Given this list of marker genes Lrp1, Tnfrsf1b, Macf1, Map2k2, Xlr3b, Caprin1, Lig4, Cxcr4, Bmpr2, Ptn, Wnt3, Vegfc (NCBI Gene Id 22341), Clcn2, Gsk3b, Smurf1, Twf2, Rheb, Synj1, Robo2, Myc, Pparg, Shtn1, Srf, Mapk8, Hdac6, Plxnb3, Cyfip1 (NCBI Gene Id 29878), Reln, Xrcc6, Dcx, Trim32, Zfp365, Il1rapl1, Golga4, Tiam1, Kdr, Ephb2, Hif1a, Hap1, Amigo1, Gh, Slc7a5, Parp6, Egfr, Aspa, Pafah1b1, Ndel1, Mir124a-3, Qki, Pak3, Anapc2, Nrp1, Mtor, Nap1l1, Il6, Fn1, Nkx2-2, Nin, Bex1, Epha4, Plxnb1, Ptk2, Etv5, Nkx2-2os, Il1b, Gper1, Kras, Prmt5, Plag1, Plxnd1, Fmr1, Vim, Oprm1, Dll3, Tgm2, Tnf, Tle6, Adcy10, Ptpra, Lif, Dlg4, Smo, Bdnf, Fbxo31, Ptprf, Fxr2, Neurl1a, Tnfrsf12a, Rab21, Spint1, Aspm, Map1b, Kit, Tbc1d24, Rufy3, Ilk, Bag1, Bhlhb9, Nr2e1, Trf, Cip2a, Grip1, Bcl11a, Srrt, Itpka, Olig2, Pax6, Igf1, Stau2, Grm5, Hdac1, Opa1, Cx3cl1, Stk11, Zfp335, Rela, Mag, Map3k13, Myo5b, Tlr2, Mdk, Akap5, Caprin2, Itgb1, Marcks, Snw1, Hdac2, Otp, Nkx6-2, Atxn1, Mir124a-2, Prkci, Bin1, Lpar3, Myb, Gfap, Rnf112, Map2k1, Csf1r, Fxn, Apoe, Lrp2, Mup20, Megf8, Metrn, Id2, Mir23a, Dct, Ace, Cdkl5, Faim, Ngf, Mfn2, Drd2, Shh, Pias2, Cxcl12, Robo1, Chodl (NCBI Gene Id 73211), Ntrk3, Disc1, Ache, Mir219a-1, Trpv2, Snap91, Ss18l1, L1cam, Tnik, Wdr62, Sox2, Zfp488, Numb, Ptprd, Bmp2, Dbn1, Eif4g2, Numbl, Vegfa, Smarcd3, Arrb2, Xrcc5, Ufl1, Dixdc1, Sgk1, Lta (NCBI Gene Id 16992), Skil, Obsl1, Ascl1, Wnt2, Kdm1a, Islr2, Eef2k, Star, Man2a1, Lyn, Fbxw8, Crabp2, Pak1, Slitrk1, Cdkl3 (cyclin dependent kinase like 3), Cask (NCBI Gene Id 236691), Plxnc1, Gjc2, Sema5a, Cux2, Dnm1l, Golga2, Kalrn, Ist1, Rpl4, Nptn, Picalm, Prkch, Ntn1, Serpine2, Slc30a1, Rnd2, Limk1, Sh3glb1, Mapt, Nog, Cdon, Sema7a, Ankrd27, Tgfb1, Efna5 (NCBI Gene Id 13640), Adnp, Tenm4, Braf, Rassf10, Il33, Egr2, Ntrk2, Dmrta2, Cdh4, Shox2, Ep300, Spen, Fxr1, Shank3, Fzd4, Wnt3a, Cysltr1, Cul7, Myrf, Arhgap32, Pou4f2 (POU domain, class 4, transcription factor 2), Plxnb2, E2f1, Sema4d, Stk25, Notch1, Trpc5 (transient receptor potential cation channel, subfamily C, member 5), Sox11, Prl2c2, Dag1, Ptprz1, Mir124a-1, Clcf1, Il6st, Tspo, Rtn4, Gsx2, Baiap2 (brain-specific angiogenesis inhibitor 1-associated protein 2), Met, Fzd3, Nefl, Khdc3, Nrdc, Il34, Zeb2, Lrp8, Sox8, Actr2, Id4, Nrg1, Xrcc2, Ppp1cc, Trp73, Dicer1, Zfyve27, Actr3 (ARP3 actin-related protein 3), Ell3, Tiam2, Ifng, Rgs14, Ntf3, Ctf2, Flt1, Trak1, Dhx36, Dbnl, Map6, Gdi1, Cux1, Fgf2, Eif2b2, Foxg1, Cx3cr1, Enpp2, Dscam, Gli3, Wnt5a, Afdn, Camk2b, Mir219a-2, Serpinf1, Mme, Wls, Xrcc4, Nkx6-1, Sox10 (NCBI Gene Id 20665), Prpf19, Mfn1, Jade2, Mecp2, Hes1, Ctnnb1, here is a description of the gene set: Any process that activates or increases the frequency, rate or extent of neurogenesis, the generation of cells within the nervous system. Mouse Gene Set: GOBP_POSITIVE_REGULATION_OF_NEUROGENESIS species: Mus musculus